The following is a description of a gene set: This event has been computationally inferred from an event that has been demonstrated in another species.<p>The inference is based on the homology mapping from PANTHER. Briefly, reactions for which all involved PhysicalEntities (in input, output and catalyst) have a mapped orthologue/paralogue (for complexes at least 75% of components must have a mapping) are inferred to the other species. electronically inferred by orthology from the curated human pathway species: Mus musculus Reactome Pathway: Signaling by CSF3 (G-CSF) part of: Cytokine Signaling in Immune system, and this is the list of marker genes: Socs3, Syk, Rps27a, Shc1, Socs1, Csf3, Rnf7, Ube2d1, Tyk2, Ubb, Grb2